The following is a description of a gene set: species: Homo sapiens from publication Bacolod MD, Johnson SP, Ali-Osman F, Modrich P, Bullock NS, Colvin OM, Bigner DD, Friedman HS (PMID 12479369) Medulloblastoma (D-341 MED) and rhabdomyosarcoma (TE-671) cell lines, which are resistant to either 1,3-bis(2-chloroethyl)-1-nitrosourea (BCNU) or the combination of BCNU and O6-benzylguanine (O6-BG), were generated by serial escalation of BCNU. The activities of O6-alkylguanine-DNA alkyltransferase (AGT), glutathione-S-transferase (GST), and total glutathione (GSH) of the parental, BCNU-resistant (BR), and BCNU + O6-BG-resistant (OBR) cells were measured. No significant differences in GST activity or total GSH were seen between the parental, BR, and OBR cells of both TE-671 and D-341 MED. The AGT activities of D-341 MED (BR) and TE-671 (BR) were twice those of D-341 MED and TE-671, respectively, confirming the importance of this enzyme for BCNU resistance. The D-341 MED (OBR) cells did not exhibit any AGT activity, suggesting that another mechanism must play a role in the drug resistance. Fewer DNA interstrand cross-links (ICLs) were observed in D-341 MED (OBR) than in D-341 MED after 8 h BCNU (100-400 microM) treatment. However, the amounts of DNA ICLs observed in D-341 MED and D-341 MED (OBR) were stable after 24 h. Microarray analysis showed the increased expressions of several metallothionein genes and down-regulation of several proapoptotic genes. The AGT activity of TE-671 (OBR) was 223 fmol/mg when the cells were grown in 10 microM O6-BG and decreased to about half this value when the O6-BG concentration was increased 60 microM. The AGT cDNA of TE-671 (OBR) cells was cloned and found to contain a G-to-T transversion at codon 156, resulting in conversion of glycine to cysteine (G156C). In vitro mutagenesis has shown that the G156C AGT mutant is resistant to inactivation by O6-BG. Thus, the selection of a mutant AGT with decreased sensitivity to O6-BG is a significant contributing factor to BCNU + O6-BG resistance. Genes down-regulated in D-341 MED (OBR) cells (medulloblastoma) resistant to both carmustine and O6-BG. Human Gene Set: BACOLOD_RESISTANCE_TO_ALKYLATING_AGENTS_DN, and this is the list of marker genes: PEG3, TUBGCP4, SMPDL3A, CXCR4, TLN2, LIG4, PHF8, CCNG1, TCEA1, YARS1, KDELR2 (NCBI Gene Id 11014), TRIM28, ARHGAP4, MEGF9, ZNF124, KHSRP, CS, PRPF4, ZC3HAV1, FZD7, OGT, SRSF2, INA, ATP2B2, TSPAN3, VCAN, LRPPRC, TUBB, UBXN7, COA1, CDC42EP1 (CDC42 effector protein 1), NREP, MTRR, PDIA2, ATRX, UBE2J1, SETDB1, SRSF1, VEZF1, MAP2K6, ATP8A1, TBR1, POLR1HASP, NHLH2, FADS1, PDCD6, PURA, PTTG1IP (PTTG1 interacting protein), ARF3, SLC25A6, CCT5, EPRS1